Given this list of marker genes GINS1, GINS3, MCM3, MCM2, MCM6, MCM7, CDC45 (cell division cycle 45), GINS4, MCM8, GINS2, MCM5, MCM4, here is a description of the gene set: Unwinding of DNA species: Homo sapiens Human Gene Set: REACTOME_UNWINDING_OF_DNA